The following is a description of a gene set: Human Gene Set: YTAAYNGCT_UNKNOWN from publication Xie X, Lu J, Kulbokas EJ, Golub TR, Mootha V, Lindblad-Toh K, Lander ES, Kellis M (PMID 15735639) studied in species Homo sapiens Genes having at least one occurrence of the highly conserved motif M168 YTAAYNGCT in the regions spanning 4 kb centered on their transcription starting sites. The motif does not match any known transcription factor binding site. Comprehensive identification of all functional elements encoded in the human genome is a fundamental need in biomedical research. Here, we present a comparative analysis of the human, mouse, rat and dog genomes to create a systematic catalogue of common regulatory motifs in promoters and 3' untranslated regions (3' UTRs). The promoter analysis yields 174 candidate motifs, including most previously known transcription-factor binding sites and 105 new motifs. The 3'-UTR analysis yields 106 motifs likely to be involved in post-transcriptional regulation. Nearly one-half are associated with microRNAs (miRNAs), leading to the discovery of many new miRNA genes and their likely target genes. Our results suggest that previous estimates of the number of human miRNA genes were low, and that miRNAs regulate at least 20% of human genes. The overall results provide a systematic view of gene regulation in the human, which will be refined as additional mammalian genomes become available., and this is the list of marker genes: ONECUT2, CSRNP3, DOCK11, CTCF, INA (internexin neuronal intermediate filament protein alpha), EIF1, SLC6A6, FNBP1L, VSTM2A, TRIM33, MEIS2, SYTL2, CD40LG, IL1RAPL1, ZFP36L1, CLVS1, VLDLR, MEPCE, PRDM13, ATP13A4, PEA15, C22orf31, LLGL2, LOXHD1, HOXB8, CREBZF, ZNF423, FGF17, NDUFA4L2, CCKAR, EFHD1, PI15, LMO4, PLPP7, HNRNPC, PTGR3, CITED1, FLRT3, HTR2C, CTNND2, PBX1, ZEB2 (zinc finger E-box binding homeobox 2), CSMD3, ACVR1C, SRSF8, NUP54, RHBDL3, ASAH1, HRK, GAD1, DCX, SLAIN1, KCNIP4, FGF7, CREM, PPARGC1A, ASB7, CXCL13 (C-X-C motif chemokine ligand 13), CCND2, PPP1R16B, LINC00305, BMF, SESN3, OSR1, PHYHIP, SLITRK2, KRT86, LDB2, DIO2, ZBTB18, ZIC4, TRIM8, PCBP2, LIMK2, TSHZ1, ZMYND8, TYRO3 (TYRO3 protein tyrosine kinase), POFUT1, H2AZ2, ASIC3, ERO1B, PLA2R1 (phospholipase A2 receptor 1), APLN, LINS1, PLAGL2, RAP2B (RAP2B, member of RAS oncogene family), TNFSF10, H2AZ1 (NCBI Gene Id 3015), EMC3, CHST15, KLHL1, PDE6D, NUDT4, DBP, CLDN3, BNC2, PTGFR, CSPG4, CHMP2B, HHEX, LUC7L2, VAMP3, FAP, LNX1, ITGB3BP, PHEX, CHRDL1 (chordin like 1), PCBP1, SAMD11, SLC26A7, WWC1, CD72, ZCWPW1 (zinc finger CW-type and PWWP domain containing 1), YRDC, WNT16, DCTN3, C1orf122, HESX1, RAB27A, H3-3B, EPSTI1, KLF14, KCNQ5, OTX2, PPP2R2B, STIM2, WAPL, POU5F1, RBMXL2 (NCBI Gene Id 27288), PTCHD1, OTX1, GATA3, ZFHX3, RHOC, EGR2, AMPH, HOXC4, ATF3, PELI2, NRXN1, HOXC6 (homeobox C6), TSHZ2, BCAR3, RPS6KB1, LUC7L3, HOXB7, AMPD3, TPI1, ZFPM2, ZBTB47, MAPK8, NR6A1, CDH13, HSD11B1